Given this list of marker genes PANK3, OSMR, ADAMTS3, ZDHHC22, EEIG1, PHYKPL, FNDC5, ACSM6, GNAL, CTNND2, SH3TC2, FAM169BP, BACH2 (BTB domain and CNC homolog 2), DIP2B, YTHDF1, CXCL12, NMNAT2, DHRS7B, SEC63, STRBP, CLEC4G, TBC1D5, HNMT, SLC18A2, MAP3K9, TRIM6-TRIM34, GPRC5A, OAS2, AKIRIN1, ZNF420, SCG3, INSR, PDE6B, PRDM10, SDHAF3, SETBP1, TCHHL1, ERLEC1, MFSD14B, EPB41L1, RUNX1, SERPINA11, AVIL, GLYAT, MBNL3, MORN3, SUPT7L, TRIM34, TCF24, CAMTA1, NEK11, UBE2H, YWHAZ, PUS7L, WDFY3 (WD repeat and FYVE domain containing 3), MORF4L1, PPP2R1B, IREB2, JMJD8 (jumonji domain containing 8), C1orf185, DDN, FAM168A (NCBI Gene Id 23201), DTX4, TAF12, STMN3, EPHA4, GSG1L, CAMK2G, NEU3 (NCBI Gene Id 10825), here is a description of the gene set: Human Gene Set: MIR1255A_MIR1255B_5P Genes predicted to be targets of miRBase v22 microRNA hsa-miR-1255a, hsa-miR-1255b-5p in miRDB v6.0 with MirTarget v4 prediction scores > 80 (high confidence targets). from publication Chen Y, Wang X (PMID 31504780) studied in species Homo sapiens